Given this list of marker genes MTA3, MATN1, ZNF529, LINC02907, SSU72L6, SLU7, NPR1, SMTNL1, ANO8, RAB11FIP3, SLC52A1, LINC00205, LINC01141, ZNF785, STXBP6, EBF3, TMEM14A, RIPPLY3, CERS3, ENPP7, PLXNB3, LINC01095, FDPSP2, DBF4B, ANKRD13C-DT, PRAP1, SERPINB3, NUAK1, DCD, TEX10, ANGPTL1, MID2, SEZ6L (NCBI Gene Id 23544), ZNF528, H1-5, DLG5, MMP24, CHRM3, ARL2, FNDC11, NOPCHAP1, MNDA, DNAH17-AS1, GSTA1, LIX1, LINC00421, SERTM1, COL12A1, TCTN3, TRPC2, ARSL, SNORD123, PRAC2, AGAP3, TBC1D12, KLK8, RNASE11-AS1, CCT6B, ADAD1, ANKEF1, MRTFB, ZNF549, RGS2, NPHP1, XRRA1, NFIA, SOX8, SSX7, CFHR3, PALD1, MAP4K3-DT, CACNA1G, MTX2, SLC10A7, CNTFR, TMEM266, DAZL, CDH16, ANKRD18A, LINC02995, PDP2, FILIP1L, KIF9-AS1, OSMR, LINC00240, OR2M4, NTN4, PARM1, CECR2, BASP1-AS1, LRRCC1, LMTK3, MIR124-2HG, PIGO, ODAM, GPX5 (glutathione peroxidase 5), C17orf50, CXCL3, COX6B2, C14orf180, DNAI4, MAP3K10, EARS2, ARHGAP11A, TAS2R41, NXF5, VWA5B1, LENEP, DLGAP1, LINC00943, DLG2, LRRC66, SLC1A7, KCNMB4 (potassium calcium-activated channel subfamily M regulatory beta subunit 4), SELL, ASB4, USP30-AS1, CCIN, CD46, FAM83F, RFPL3, LY6E-DT, RBM15B, FLT4, DUSP4 (dual specificity phosphatase 4), C11orf65, VSTM2A-OT1, SUB1, CCDC122, MIR4500HG, ADAMTS2, C2CD6, KLK14, SOX7, GPRC5D-AS1, CSMD2, IFRD2 (interferon related developmental regulator 2), NSMCE1-DT, SLC45A1, ESPN, TCF21 (NCBI Gene Id 6943), SLITRK1, CTSLP8, KCNA1, TGFB3, RAP1A, CRYBA1, MFSD4A-AS1, CCK, PIWIL2, SLC7A10, SLC25A48-AS1, DGCR5, LINC00330, GPD1, ENSG00000249695, NALT1, SF3A2, LSM11, HMHB1, ZNF876P, OLFM1, LINC01550, JAKMIP1, TPO, PLA2R1 (NCBI Gene Id 22925), FAM169BP, SETMAR, C5orf46, LINC01121, AXL, RAPH1, CCDC86, JPH1, TMEM54, PRSS50, ATP1A4 (NCBI Gene Id 480), ORC1, MAGI1-IT1, TMEM196, TRHDE-AS1, TBC1D22A-AS1, CALN1, IGFBPL1, OR3A1, DLGAP2-AS1, CCDC42, DDX53, DISP3, here is a description of the gene set: species: Homo sapiens Genes down-regulated in comparison of control polymorphonuclear leukocytes (PMN) at 0 h versus PMN treated with F. tularensis vaccine at 0 h. from publication Schwartz JT, Bandyopadhyay S, Kobayashi SD, McCracken J, Whitney AR, Deleo FR, Allen LA (PMID 22986450) Human Gene Set: GSE37416_CTRL_VS_0H_F_TULARENSIS_LVS_NEUTROPHIL_DN We demonstrated recently that both constitutive and FAS-triggered apoptosis of human neutrophils are profoundly impaired by Francisella tularensis, but how this is achieved is largely unknown. To test the hypothesis that changes in neutrophil gene expression contribute to this phenotype, we used human oligonucleotide microarrays to identify differentially regulated genes in cells infected with F. tularensis strain LVS compared with uninfected controls. In order to examine the effect of F. tularensis on the neutrophil transcriptome, we performed microarray expression analysis on human neutrophils treated with F. tularensis subsp. holarctica live vaccine strain (LVS).